The following is a description of a gene set: species: Mus musculus Genes predicted to be targets of miRBase v22 microRNA mmu_miR_6927_5p in miRDB v6.0 with MirTarget v4 prediction scores > 80 (high confidence targets). from publication Chen Y, Wang X (PMID 31504780) Mouse Gene Set: MIR_6927_5P, and this is the list of marker genes: Srsf1, Copz1, Sumo1, Csf1, Atp8b2, Aldh3a2, Gnb1, Col1a1, Szrd1, Zdhhc9, Ark2c, Arap3, Nkd2, Caln1, Asgr1, Samd4b, Mbnl3, Ttc14, Ccdc103, Cep120, Ypel1, Rnf214, Fech, Nono, Lsm11, Cmklr1, Shank1, Mras, Xpr1, Gimap3 (GTPase, IMAP family member 3), Grik3, Bgn, Lgalsl, Acsbg2, Cdip1, Ang, Foxp4, Klrg2, Tbx22, Klhdc8a, Grhl2, Pak3 (p21 (RAC1) activated kinase 3), Btnl2, Nudcd3, Tmem253, Acsf2, Mif4gd, Mycbp